The following is a description of a gene set: Mouse Gene Set: GOCC_I_BAND species: Mus musculus A region of a sarcomere that appears as a light band on each side of the Z disc, comprising a region of the sarcomere where thin (actin) filaments are not overlapped by thick (myosin) filaments; contains actin, troponin, and tropomyosin; each sarcomere includes half of an I band at each end., and this is the list of marker genes: Kcnn1, Xirp2 (xin actin-binding repeat containing 2), Pgm5, Kcna5, Cacna1c (calcium channel, voltage-dependent, L type, alpha 1C subunit), Scn1a, Nos1, Scn8a, Pdlim2, Cav3, Fhod3, Ky, Ankrd2, Slc8a1, Myzap, Syne2, Pak1, Mypn, S100a1, Flnb, Asb2, Fhl3, Fermt2, Fkbp1a, Homer1 (homer scaffolding protein 1), Akap4, Parva, Ctnnb1, Rem1, Tjp1, Ankrd1, Ldb3, Capn3, Des, Frg1, Csrp2, Sptan1, Casq1, Cryab, Obscn, Kcnn2, Trim63, Psen2, Ggps1, Cfl2, Pygm, Atp2b4, Hspb1, Myot (myotilin), Scn3b, Sphkap, Adra1a, Anxa5, Aldoa, Actn4, Tcap, Kat2b, Glrx3, Myl12a, Myl12b, Hdac4, Trim54, Casq2, Palld, Nexn, Bin1, Flnc, Myl3, Fbxo22, Sri, Stk11, Smtnl1, Neb, Actn3, Synm, Dst, Actc1, Pdlim7, Kcnn3, Myoz2, Synpo2, Parvb, Hrc, Sync, Itgb1bp2, Myo18b, Pdlim4, Synpo, Fhl5, Pdlim1, Nos1ap, Slc4a1, Csrp1, Ank3, Flna, Kcne1, Nrap, Ryr1, Ppp3cb, Pdlim5, Rtn2, Unc45b (NCBI Gene Id 333681), Polr2m, Slc2a1, Ppp3ca, Nebl, Jph1, Slmap, Igfn1, Fbxl22, Actn1, Cacna1s, Cacna1d, Sorbs2, Ppp1r12a (NCBI Gene Id 71736), Krt19, Ank1, Actn2, Myoz3, Bmp10, Cab39, Myl9, Krt8, Dmd, Myh7 (NCBI Gene Id 17889), Myoz1 (NCBI Gene Id 80553), Vcl (NCBI Gene Id 268722), Pgm1, Atp2a1, Plec, Cavin4, Csrp3, Ryr3, Myh6, Klhl40, Prickle4, Ryr2, Dnajb6, Ppp2r5a, Grin2b, Stub1, Pdlim3, Ankrd23, Ttn, Smn1 (NCBI Gene Id 20595), Grk3, Fhl2, Fbp2, Jph2, Ank2, Ppp1r12b, Fbxo32, Prkd1, Scn5a, Mtm1, Jup, 3425401B19Rik, Capzb, Tuft1, Kbtbd13, Synpo2l, Rtl1, Dnajb4, Bag3, Fkbp1b